Given this list of marker genes Pfpl, Cftr, Robo2, Bzw1, Gm2042, Tlk2, Smox (spermine oxidase), Bend4 (BEN domain containing 4), Epb42, Ctdspl2, Ncor1, Fgf13, Enc1, Plxnc1, Magoh, Apobec3, Slc25a36, Sgcd, Il6st, Tslp, Sc5d, Eif4a3l1, C1d, Kcmf1, Kmt2c, Neto1, Smad5, Nrep, P2ry10b, Zfp131, Cadm1, Grik3, Srf, Cnot6l, Med26, Osgep, Col1a2, Akap17b, Taok1, Pcdh9, Impa1, Tm2d1, Itpka, Hccs, Pyurf, Slc12a2, Tafa5, Tmem43, Cabyr, Gk5, Dpp8, Thrb, Bicc1, 1700129C05Rik, Per3, Gpatch2l, Dnajb11, Sod2, Ankrd44, Traf2, Acly, Map2k7, Hlf, Rusc1, Herc2, here is a description of the gene set: Genes predicted to be targets of miRBase v22 microRNA mmu_miR_6989_3p in miRDB v6.0 with MirTarget v4 prediction scores > 80 (high confidence targets). from publication Chen Y, Wang X (PMID 31504780) Mouse Gene Set: MIR_6989_3P studied in species Mus musculus